Given this list of marker genes Aldh1a2 (NCBI Gene Id 19378), Rbp1, Scarb1, Crabp2, Rarb, Rdh10, Cyp26b1, Crabp1, Rdh8, Rbp7, Cyp26a1, Rara (NCBI Gene Id 19401), Rdh12, Rdh5, Dhrs3, Sult1a1, Bco2, Rxrg, Sult2b1, Rarg, Bco1, Rbp2, Cd36, Lrat, Aldh1a3, Adh1, Lpl, Aldh1a1, Retsat, Abcg5, Rbp4, Rlbp1 (retinaldehyde binding protein 1), Rxra, Abcg8, Rpe65, Cyp2e1, Rxrb, Npc1l1, Adh4, here is a description of the gene set: Retinol metabolism species: Mus musculus Mouse Gene Set: WP_RETINOL_METABOLISM